Given this list of marker genes Col6a5, Tnr, Col6a6, Col2a1, Hapln1, Bgn, Acan, Itga2, Col6a1, Tnc, Itga2b, Vtn, Tnxb, Col9a1, Itgax, Tnn, Col5a3, Dcn, Itgb5, here is a description of the gene set: species: Mus musculus part of: Extracellular matrix organization Reactome Pathway: ECM proteoglycans This event has been computationally inferred from an event that has been demonstrated in another species.<p>The inference is based on the homology mapping from PANTHER. Briefly, reactions for which all involved PhysicalEntities (in input, output and catalyst) have a mapped orthologue/paralogue (for complexes at least 75% of components must have a mapping) are inferred to the other species. electronically inferred by orthology from the curated human pathway